The following is a description of a gene set: Mouse Gene Set: GOBP_PEPTIDE_ANTIGEN_ASSEMBLY_WITH_MHC_CLASS_I_PROTEIN_COMPLEX species: Mus musculus The binding of a peptide to the antigen binding groove of an MHC class I protein complex. Class I here refers to classical class I molecules., and this is the list of marker genes: Tapbp, Calr, Tapbpl, Pdia3, B2m